The following is a description of a gene set: Mouse Gene Set: ING1_TARGET_GENES Genes containing one or more binding sites for (Ing1) in their promoter regions (TSS -1000,+100 bp) as identified by GTRD version 20.06 ChIP-seq harmonization. from publication Yevshin I, Sharipov R, Kolmykov S, Kondrakhin Y, Kolpakov F (PMID 30445619) studied in species Mus musculus, and this is the list of marker genes: Ppih, Idh1, Oscp1, 1600023N17Rik, Psmd12, Cdca8, Lrr1, Ipo11, Pou2f1, Man2c1, Rcc1, Kif2c, Pola2, 9330154J02Rik, Ubfd1, Smad7, Galnt17 (NCBI Gene Id 94250), Lrig3, Lrig1, Tm9sf3, Mybl1 (NCBI Gene Id 17864), Diaph3, Fasn, Gm10501, Trpm8, Zfpl1, Arhgef39, Kctd9 (potassium channel tetramerisation domain containing 9), Smc2, 4933430I17Rik, Arhgap11a, Reno1, Rad51, Scfd2, Mettl4, Wee1 (NCBI Gene Id 22390), Mis18a, Dlgap5, Hspd1, 1700125G22Rik, Smc2os (NCBI Gene Id 72648), Tlk2, Adpgk, Cpeb2, Foxm1, Hsp90aa1, Knl1, Pxmp2, Pole3, Nmrk1, Kpna2, Hjurp, Mki67, Cep128, Cep126 (centrosomal protein 126), Efcab11, Ttk, Trmt61a, Cdc20, Mcm8, Tpx2, Krit1, Nup107, Gle1, Sass6, Gm10941, Pbk, Nek2, 2010110K18Rik, Man2c1os, Atp5pb, Airim, Blcap, Net1, 1700052K11Rik, Mybl2, Atg16l1, Srgap2, Mms22l, Ramac, Tex30, Tbx15, Nr4a2, Wdr62, Ankib1, Plk1, Pikfyve, Cdca2, Ccne2, Pomt1, Rrm2, Clspn, Atad2, Hmg20a, Hrob, Gm14023, Lsm2, Aplp2, Ncapg2, Ckap2l, Pofut2, Hspe1, Gm11457, Cdca5, Rhno1, Sgo2a, Gm13610, Pole, Ears2, 2700099C18Rik, Taf4b, Syncrip, Polq, Nup85, Trmt13, Aurkb, Ticrr, Kif11, Igf1r, Gm15489, Ube2c, Trmt6, Rnf181, Tedc1, Fbxo5, Apbb2, Ect2, Cdc25c